Given this list of marker genes ARHGDIG, B3GALNT1, SLC38A11, RAB27B, CTH, ACE, GYS2, MIR448, HORMAD2, EMP2, PCDHB17P, TRIM72, VBP1, HEBP2, NPNT, GSDME, UROS, P4HA3, THSD1, NECAB2 (N-terminal EF-hand calcium binding protein 2, NCBI Gene Id 54550), CRYBB1, GARIN1A, GUCY1B2, ARHGAP36, PTH2, KRT12, TRPM5, DENND6B, NETO1, RGS9, BMPR1B, PNMA3, COL23A1, DUSP21, MARVELD3, TBX5, HMGN2P6, RAB18, FER1L6, THNSL2, CYP26B1, GTSF1, MIR455, ALDH3B1, VLDLR, ASPG, MAP3K9, PLPP3, NAPSA (NCBI Gene Id 9476), TPI1, TSLP, ACTBL2, CCDC33, DERA, ZGLP1, DRG1, B3GNT8, C7, NIP7, MICAL2, PLEKHH2, EGF, TMEM229A, MARCHF1, FGFR4, CYGB, MDGA1, MGAT3 (NCBI Gene Id 4248), GAP43, DACT2, KCNQ1 (NCBI Gene Id 3784), MSLN (mesothelin), TMEM217, TMEM126B, EEF1AKMT1, FAT3, EGFR, GCKR, PIWIL4 (NCBI Gene Id 192673), NOL7, PSMA8 (proteasome 20S subunit alpha 8), CIDEC, TMPRSS11A, MIR378A, FCGR2B, KRTAP26-1, MIR543, TEKT1, CYP2G1P, NOTCH4, DISC1, FGF12, MIR370, CDH7, RPS11, SLC38A4, OSGEPL1, PXDN, ACE2, POPDC3, BMP2, SPINK5, CPB2, TSPAN7, FSHB, LIPH, SLC2A5, MIR7-1, MYO16, SLC34A3, TMCC2, PDZK1IP1, GPHA2, TRIM50, TMEM17, PLIN5, COPZ2, TAF1D, LELP1, CLEC4F, SFXN2, CACNG3, here is a description of the gene set: Genes down-regulated in mature inhibitory dendritic cells: L. monocytogenes infection versus prostaglandin E2. from publication Popov A, Driesen J, Abdullah Z, Wickenhauser C, Beyer M, Debey-Pascher S, Saric T, Kummer S, Takikawa O, Domann E, Chakraborty T, Krönke M, Utermöhlen O, Schultze JL (PMID 18802101) species: Homo sapiens Human Gene Set: GSE9946_LISTERIA_INF_MATURE_VS_PROSTAGLANDINE2_TREATED_MATURE_DC_DN Myeloid dendritic cells (DC) and macrophages play an important role in pathogen sensing and antimicrobial defense. Recently we demonstrated that infection of human DC with intracellular bacterium Listeria monocytogenes (L.monocytogenes) leads to the induction of the immunoinhibitory enzyme indoleamine 2,3-dioxygenase (Popov et al., J Clin Invest, 2006), while in the previous studies L.monocytogenes infection was associated with a rather stimulatory DC phenotype. To clarify this discrepancy we performed comparative microarray analysis of immature mo-DC (immDC), mature stimulatory mo-DC (matDC) and mature inhibitory DC either stimulated with prostaglandin E2 (PGE2-DC) or infected with L.monocytogenes (infDC). Studying infection of human myeloid DC with Listeria monocytogenes, we found out, that infected DC are modified by the pathogen to express multiple inhibitory molecules, including indoleamine 2,3-dioxygenase (IDO), cyclooxygenase-2, interleukin 10 and CD25, which acts on DC as IL-2 scavenger. All these inhibitory molecules, expressed on regulatory DC (DCreg), are strictly TNF-dependent and are in concert suppressing T-cell responses. Moreover, only DCreg can efficiently control the number of intracellular listeria, mostly by IDO-mediated mechanisms and by other factors, remaining to be identified. Analyzing publicly acessible data of transcriptional changes in DC and macrophages, infected by various pathogens and parasites (GEO, GSE360), we noticed that infection of these cells with Mycobacterium tuberculosis causes transcriptional response, comparable with the one caused by listeria in human DC. In fact, granuloma in tuberculosis and listeriosis in vivo are enriched for myeloid DC and macrophages characterized by regulatory phenotype. In summary, regulatory myeloid DC and macrophages may play a dual role during life-threatening granulomatous infections, such as tuberculosis: on one hand, regulatory myeloid cells promote pathogen containment by efficiently killing intracellular bacteria, on the other hand these cells inhibit granuloma-associated T cells and thereby might be involved in the retention of TNF-controlled granuloma integrity protecting the host from granuloma break-down and pathogen dissemination.